The following is a description of a gene set: Elevated circulating aspartate aminotransferase concentration Human Gene Set: HP_ELEVATED_CIRCULATING_ASPARTATE_AMINOTRANSFERASE_CONCENTRATION The concentration of aspartate aminotransferase (AST) in the blood circulation is above the upper limit of normal. species: Homo sapiens, and this is the list of marker genes: ASL, ATP7B, FHL1, PRKCD, MRPL3, EARS2, MRPL44, TMEM165, VPS13A, SLC37A4, NR1H4, STX5, B4GALT1, PEX2, CAV3, SLC51B, SLC2A2, HMGCL, MARS1, LYN, DNAJC19, DEF6, TMEM199, APOE, MPV17, ATP6AP1, MRPS2, NSMCE2, HMGCR, PSMB9, ACOX2, IFT56, SLC22A5, TWNK, CPT2, UQCRB, GBA1, DOCK2, LYRM4, SCO1, CYP7B1, SC5D, PEPD, TANGO2, MYO5B, VPS33B, AMACR, SEMA7A, HADHB, PEX14, TRMT10C, SLC25A13, SUCLG1, AHCY, IARS1, PIGL, OTC, LARGE1, HMGCS2, COG7, POLG2, LMNA, VPS50, NFS1, RRM1, COG8, KIF12, LIPA, APOB, RRAGC, DPYS, GALT, HADHA, CPT1A, UBR1, SMPD1 (NCBI Gene Id 6609), BAAT, USP53, PGM1 (NCBI Gene Id 5236), OCRL, WRN, HMOX1, PEX16, MOGS, XK